Given this list of marker genes MT1M, MT3, MT1H, MT1E (metallothionein 1E), MT2A, MT1F, MT4, MT1G, MT1B, MT1X, MT1A, here is a description of the gene set: Human Gene Set: REACTOME_METALLOTHIONEINS_BIND_METALS species: Homo sapiens Metallothioneins bind metals